Given this list of marker genes UCMA, NCALD, PIP5KL1, NEDD9, EXOC6, ID4, ESR2, PDPR, GABRE, ETV6, TMEM199, TNRC6B, EVC, CXCL12, SGO1, ARHGAP17, DDI2, ONECUT2, SPTBN1, FABP7, TRNP1, NAV3, UBE2Z, TUBB4A, ZNF266, CCDC25, ZNRF3 (NCBI Gene Id 84133), SETD3, ZNF93, NR2F2, NFASC, AGO2, RAB30, AAK1, FXR1, LILRB4, ADAMTS19, ZNF609, TDRD6, TLN1, ATP6V0B (ATPase H+ transporting V0 subunit b), BEND3, TENT2, DPH5, GLUD1, SUPT7L, NDRG1, SAMD12, MAX, RAPGEF1, DNAJC6, SPIN1, HSDL2, SEC24A, CFL1, here is a description of the gene set: Genes predicted to be targets of miRBase v22 microRNA hsa-miR-6503-5p in miRDB v6.0 with MirTarget v4 prediction scores > 80 (high confidence targets). studied in species Homo sapiens Human Gene Set: MIR6503_5P from publication Chen Y, Wang X (PMID 31504780)